The following is a description of a gene set: Mouse Gene Set: GOMF_ADENYLATE_CYCLASE_ACTIVATOR_ACTIVITY studied in species Mus musculus Binds to and increases the activity of adenylate cyclase., and this is the list of marker genes: Raf1, Calm3, Gnas (NCBI Gene Id 78290), Calm2, Calm1